The following is a description of a gene set: Polycomb group (PcG) proteins form multiprotein complexes, called Polycomb repressive complexes (PRCs). PRC2 contains the PcG proteins EZH2, SUZ12, and EED and represses transcription through methylation of lysine (K) 27 of histone H3 (H3). Suz12 is essential for PRC2 activity and its inactivation results in early lethality of mouse embryos. Here, we demonstrate that Suz12(-/-) mouse embryonic stem (ES) cells can be established and expanded in tissue culture. The Suz12(-/-) ES cells are characterized by global loss of H3K27 trimethylation (H3K27me3) and higher expression levels of differentiation-specific genes. Moreover, Suz12(-/-) ES cells are impaired in proper differentiation, resulting in a lack of repression of ES cell markers as well as activation of differentiation-specific genes. Finally, we demonstrate that the PcGs are actively recruited to several genes during ES cell differentiation, which despite an increase in H3K27me3 levels is not always sufficient to prevent transcriptional activation. In summary, we demonstrate that Suz12 is required for the establishment of specific expression programs required for ES cell differentiation. Furthermore, we provide evidence that PcGs have different mechanisms to regulate transcription during cellular differentiation. Human Gene Set: PASINI_SUZ12_TARGETS_DN Genes down-regulated in ES (embryonic stem cells) with defficient SUZ12. from publication Pasini D, Bracken AP, Hansen JB, Capillo M, Helin K (PMID 17339329) studied in species Mus musculus, and this is the list of marker genes: LPGAT1, RYK, PEA15, ITGA3, MYH10, FOXP1, REEP3, SKIL (SKI like proto-oncogene), POU3F1, RPS6KA3, PHC2, LTB (NCBI Gene Id 4050), GNAS, IER3, SERPINB9 (serpin family B member 9), WLS, YAF2, AMFR, KCTD10, CTXN1, PARVA, SELENOW, TAGLN, MARCKS, SOX4, FARP1, CMTM7, CNN2, GRB10, CITED2, TBXT, SFN, COL1A2, ANXA5, CDH2, TMEM30A, IRS1, KLHDC2, CLDN12, TPM1, ANXA1, SEMA3C, CSN3, PITX2, TCF12, TAX1BP3, NT5E, MEG3, DBN1, ITGB1, SCD, AHNAK, PLIN2, GHR, PHLDA1, FAM107B, MYO1C (NCBI Gene Id 4641), COL11A1, MTPN, IGFBP4 (insulin like growth factor binding protein 4), UBE2E1, GPRC5A, RBMS1, ELOVL1, SPSB1, TENM3, CCNG1, ZNF266, SDC1, SYT11, ARAP3, RND3, ABHD2, IGFBP3, ARL4C, SEMA3E, BAZ1A, TMEM47, TPM4, CSNK1G1, CDKN1A, EFEMP1, DUSP1 (dual specificity phosphatase 1), COLEC12, LOXL2, CCN1, ACTN1, WNT4, FRMD4B, EPHA1, STEAP1, KPNA4, DOCK11, SUZ12, PLK2, FN1 (NCBI Gene Id 2335), FLRT3, NPNT, SOX11, PRICKLE1, MALAT1 (metastasis associated lung adenocarcinoma transcript 1), SLC25A24, HMGN3, CD24, KLF7, AMMECR1L, TMPRSS2 (transmembrane serine protease 2), PERP (p53 apoptosis effector related to PMP22), KLF6, MSN, ACSL4, PALLD, TCEAL8, PKIA, GNG12, PPP1R18, CRMP1, RRAS2, GAP43, PXDN, LRRFIP1, TSPAN9, CRLF1, VCAN, KRT18, ADK, DSP, MYADM, PHLDB2, LIMD2, CAPN2, BHLHE40, CNN1, CPE, SERPINH1, GLIPR2 (NCBI Gene Id 64148), CMTM3 (CKLF like MARVEL transmembrane domain containing 3), STEAP2, PPBP, CD151, FZD2, CORO1C, ACTC1, ZDHHC9, CGN, VAT1, PDLIM3, CAV1, PRTG, CFL2, PHIP, ERRFI1, UBE2J1, HMGA2, STMN2, LHFPL6, PRPF40A, EID1, IGFBP5 (NCBI Gene Id 3488), PIK3R3, DUSP6 (NCBI Gene Id 1848), CALD1, RAP2B, AXL, WNK1, NUAK1, GSN, RBP1, SYNPO2L, TMBIM1, SLC39A6, COL3A1, PWWP3B, ABRACL (NCBI Gene Id 58527), ID2 (NCBI Gene Id 3398), AMOTL2, WWTR1, PRNP, KRT19, JAG1, STX6, PAWR, PLOD2, FILIP1L, LIMD1, IRS2, COL1A1, S100A6, FOSL2, COL4A5, BMP2, CAVIN1, THBS1, ACTA1, ACTA2, RCN2 (reticulocalbin 2), ELOC, GLI3, DCBLD2 (NCBI Gene Id 131566), TMEM123, ETS1, SULF1, JUN, TUBB6, TMCC3, ZYX, GNG3 (G protein subunit gamma 3), TUBA1A, KRT8, LPP, METRNL, SOCS6, AIF1L, ABTB2, MYC, IER5, TMEM43, NR6A1, SP5, BNIP2, CCN4, COL5A1, PKP2, BDNF, SETD7, TNFRSF19, SCOC, ANXA2, APP, RO60, BACH2, PDLIM5, PDGFB, CLIC1, TPM2, TIMP2, LGALS1, SH3BGRL, RHOB, PMP22, B2M, CYFIP2, HBEGF, DDX6, TTYH3, NEFL, DPYSL2, PRSS23 (NCBI Gene Id 11098), KLHL9, MLLT11, LPAR4, TNFRSF12A, GBP2, NCS1, CA3, VIM, ITGAV, TES, MEG8, SHB, TGFB1I1, LRP8, BMP4, SH3GLB1, MMP14, GNG2 (G protein subunit gamma 2), PROM1, SAMD4A, ANXA3, POGLUT2 (NCBI Gene Id 79070), VCL, FLNA, TRIB1, ZMYND8, F3, AMOTL1, NREP, HS6ST2, CD276, SOAT1, CAV2, TSPAN2, DUSP14, CRYAB, SH3PXD2A, CAP1, CSF1, AKT1, RHOBTB3, TGFB2, CSRP1, SERTAD4, CYP1B1, RDH10, DYRK2, SMO, RAB34, CDKN2B, PDLIM7, CXADR, EFNA5, S100A10, ILK, HACD1, BMP1, IDI1, VGLL3, CDK6, GMFB, KIF5C, MARVELD2, BTG2, RTN3, LRATD2, PTPN12, FLNC